The following is a description of a gene set: Cytokines mediate cell-cell communication in the immune system and represent important therapeutic targets. A myriad of studies have highlighted their central role in immune function, yet we lack a global view of the cellular responses of each immune cell type to each cytokine. To address this gap, the authors created the Immune Dictionary, a compendium of single-cell transcriptomic profiles of more than 17 immune cell types in response to each of 86 cytokines (>1,400 cytokine-cell type combinations) in mouse lymph nodes in vivo. A cytokine-centric view of the dictionary revealed that most cytokines induce highly cell-type-specific responses. For example, the inflammatory cytokine interleukin-1β induces distinct gene programmes in almost every cell type. A cell-type-centric view of the dictionary identified more than 66 cytokine-driven cellular polarization states across immune cell types, including previously uncharacterized states such as an interleukin-18-induced polyfunctional natural killer cell state. Genes negatively differentially expressed in cell type: MigDC (migratory dendritic cell) upon treatment with cytokine: TL1A in mouse lymph nodes in vivo. studied in species Mus musculus Mouse Gene Set: CUI_MIGDC_TL1A_RESPONSE_DN from publication Cui A, Huang T, Li S, Ma A, Pérez JL, Sander C, Keskin DB, Wu CJ, Fraenkel E, Hacohen N (PMID 38057668), and this is the list of marker genes: Mt1, Synpo2, Hspa1a, Ccr7, Fos, Sema6d, Ubc, Tnfrsf1b, Pfkfb3, Zfp36, Mxd1, Dusp1, Rgs1